Given this list of marker genes PSEN1, HERC6, PLAGL1, IRF7, NT5C2, CFB, EBAG9, HLA-J, ELF4, ZFPM2, PRKD2, CELA3B, KLF11, DAPK1, LGALS8 (NCBI Gene Id 3964), NT5E, IFI35, IFIT3, SMARCA5, SCN5A, PARP12, MYD88 (NCBI Gene Id 4615), CMTR1, DKK1, SLC22A18, KCTD14, HK2, OASL, TIPIN, PARP4, CNP, CD47, PPP2R2A, TRIM5, RUSC1, SPRY2, IFITM1, BAG1, NMI, LY6E, IFI6, KANK3, NBN, IFIT1, LMO2, FMR1 (fragile X messenger ribonucleoprotein 1), ADAR, JADE2, TDRD7, HLA-C, KLF17P1, PLEKHA4, EFR3A, RIGI, SH2B3, MX2, WASHC4, TMEM62, IFI44, DNAJC24, NAPA, RASGRP3, PLSCR1, THEMIS2, GCH1, IFI27, DEDD, UNC93B1, UBA7, B2M, SLC15A3, IFIT2, ID3, DGCR11, HERC5, PSMB9, RSAD2, IFITM2, TRIM38, EIF2AK2, GCNT1, IFIT5, CEP112, COMMD8, PML, PSMB8 (NCBI Gene Id 5696), ELF1, SUOX, SUGP1, HLA-B (major histocompatibility complex, class I, B), FHL3, RAPGEF5, STK24, MSX1, HOXD3, RBCK1, TENT5A, KAT2B, SP110, PRDM11, TRIM25, DDIT4, BCL2L13, SAMHD1, BTG3, P2RX1 (purinergic receptor P2X 1), TNFSF18, FBXL7, TNFSF10, ERBB3, SAMD9, MYCBP2, ISG15, EHD4, OGFR, ZCCHC2, CBR3 (carbonyl reductase 3), DDO, PDZD2, APOBEC3G, TRIM26, HLA-F, SOCS2, GHRHR, SHFL, VEZF1, SCAMP1, XAF1, TREX1, SPATS2L, SNX11, ESM1, TFDP3, RAB9A, PDXK, CYP2J2, PGAM1, MEF2C, CTNNBL1, BST2, ZNF467, GTPBP2, USP18, TNFRSF11A, TRANK1, SIDT2 (NCBI Gene Id 51092), RTP4, GYG1, BLZF1, TMEM50A, IFIH1, MX1, OAS2, AMOTL2, UVRAG, ELOVL6, ISG20, RPS6KC1, DHX58, AFAP1, LTB4R2, NFYB, LGMN, SLC25A28, IFITM3, IFI44L, CTNND2, CAV1, TARBP1 (NCBI Gene Id 6894), PPIC, OSBPL7, B4GALT4 (beta-1,4-galactosyltransferase 4), RIN2, TRIM14, PHF11, USP25 (NCBI Gene Id 29963), SPTLC2, SEMA6A (semaphorin 6A), NGFR (NCBI Gene Id 4804), ZFYVE26, YEATS2, LGALS9, CASP1, IFI16, CD164, LNPEP, EML2, TNS4, N4BP1, TLE4, DDX60, TRADD, NR3C1, OAS1, OAS3 (2'-5'-oligoadenylate synthetase 3), TOR1B (torsin family 1 member B), NME7, CCDC85B, UBE2L6, RABAC1, here is a description of the gene set: We identified Pparg as a major orchestrator of the phenotype of adipose-tissue resident regulatory T cells (VAT Tregs). To explore the contribution of Pparg1 and 2 in the generation of the VAT Tregs-specific gene signatures, CD4+FoxP3- T cells were transduced with Foxp3+/- Pparg1 (or Pparg2), treated with Pioglitazone or vehicle, and double sorted for microarray analysis. Genes up-regulated in CD4 T cells treated with pioglitazone and over-expressing: FOXP3 and PPARg1 isoform of PPARG versus FOXP3. from publication Cipolletta D, Feuerer M, Li A, Kamei N, Lee J, Shoelson SE, Benoist C, Mathis D (PMID 22722857) Human Gene Set: GSE37533_PPARG1_FOXP3_VS_FOXP3_TRANSDUCED_CD4_TCELL_PIOGLITAZONE_TREATED_UP species: Homo sapiens